The following is a description of a gene set: from publication Chen Y, Wang X (PMID 31504780) studied in species Homo sapiens Human Gene Set: MIR5585_3P Genes predicted to be targets of miRBase v22 microRNA hsa-miR-5585-3p in miRDB v6.0 with MirTarget v4 prediction scores > 80 (high confidence targets)., and this is the list of marker genes: CCDC82 (coiled-coil domain containing 82), LIN54, ZNF180, ZSCAN25, IGFBP5, FBXO4, GALNT18, LNX1, SH3TC2, PPARGC1A, GSPT1, PALS2 (protein associated with LIN7 2, MAGUK p55 family member), CRYBG1, NEUROG1, API5, PYROXD1, HNRNPR, MOBP, PRSS37, LCN15, COL10A1, SLC19A2, MT1B, MDH1, MAB21L1, STRN, ETFRF1, MROH9, ADGRG6, EIF2S1, NRG3, INTU, PRKCE, ASB9, SLC4A7, KL, TMEM135, KERA, SRSF7, MIPOL1, FAM169BP, ARHGAP5, CYBB, RGL4, CHCHD3, ZNF624, FAM217A, XRCC4 (X-ray repair cross complementing 4), MARK1, SGCZ, CADM2, DIP2A, AOC3, PIGA, RAB3GAP1, WT1, ARL6IP6, ROBO2, LARP4, PIKFYVE, SOS2, RBM24, SEC24A, INSM1, SGIP1, ZC2HC1A, BRIP1, EFCAB7, THRB, CASP14, ESYT2, EIF4A2, PIK3R4, CTSK, AIFM1, TTN, FYB1, HMBOX1, SLC17A9, PXYLP1, CNTN1, URI1, SMARCA1, PIN4, SYNPO2, LIMA1, KLHL15, RNF2, ABCA1